Given this list of marker genes CD164, PRMT1, CCNA2, PTMA (NCBI Gene Id 91418), DYNC2I2, TES, FABP5, MYH2, ATAD2, RPS3A, CKS2, CCT5, URI1, ACTL6A (NCBI Gene Id 9178), RPL17, S100A6, RPS7, TSPAN3, AGFG1, MCM7, ZWILCH, YWHAH, DEK, RWDD1, ZNF37BP (NCBI Gene Id 7588), UBA2, CENPU, YBX3, IER3, HDDC2 (NCBI Gene Id 51020), RPS11P1, DYRK2, TUBA1B, ATP5F1C, GTPBP4, ZNF138, RPL31, RBX1 (ring-box 1), RPL35, DYNLT1, RMI2, SMC2, RPL38, MTHFD2 (methylenetetrahydrofolate dehydrogenase (NADP+ dependent) 2, methenyltetrahydrofolate cyclohydrolase), RALA (NCBI Gene Id 5898), TPRKB, ANLN, HNRNPA1, TMSB4X, LRRCC1, TOPBP1, VCL, PTGR3, CCNB1, DCTPP1, DYNLL1, YWHAQ, B3GNT5, RPS18, HNRNPC, OLIG2, LSM8, RPE, RPL27, H4C1 (NCBI Gene Id 8359), CDK4, SLBP, LYAR (Ly1 antibody reactive), PRMT2, BCAT1, PTBP3, ACTR3, ECT2, EIF4A3, KLF5, MRPL42, VCP, PCLAF, RPS5, CENPF (NCBI Gene Id 51468), DBNDD2, H4C3, SNRPG, CDCA8, RPL9, JPT1, RPS6, MSH6, LAMB1, INAVA, DEPDC1, TTK, RPS3, MFSD10, SUMO2, NFE2L3, YWHAB, RBM17, ANXA3, CD2AP, ITGB1BP1, CTBP2, UBE2T, SNRPB2, PELI1, SLC34A1, SERPINH1, KIF5B, HMGB2, PNP, ARHGAP18, RGS2 (NCBI Gene Id 5997), OPLAH, SFT2D1, BUB3, PHLDA2, LXN, NTS, SLC44A1, NSF, RAN, CALM2, DLGAP5, MCM6, MAPRE1, KNTC1, MARCKS, KRT10, METTL5 (methyltransferase 5, N6-adenosine), ZNF532, DSG2, ANXA4, PCNA, PBX1, MMD, SPC25, CBX3, RPL36A, PDCD5, RCC2, FBL, NLRP2, ATP2B1 (NCBI Gene Id 490), NOP56, HIF1A, SET, RAB32, UBE2D1, ZNF681, EEF1E1, NAP1L1, KRT19, ODC1, CLIC1, NDC1, RPL12, RPSA, ITPR3, NPM1, PFDN4, HMGN1, BZW2, HDAC2, IGF1R, USP1, RPS9, CCDC6, SUZ12, SEPTIN7, PDLIM7, PLP2, MCM2, NCBP2, ZC2HC1A, H4C14, RND3 (Rho family GTPase 3), CCT6A, KHDRBS1, AGRN, DUSP18, here is a description of the gene set: Genes highly expressed in hepatocellular carcinoma with poor survival. Human Gene Set: LEE_LIVER_CANCER_SURVIVAL_DN species: Homo sapiens from publication Lee JS, Chu IS, Heo J, Calvisi DF, Sun Z, Roskams T, Durnez A, Demetris AJ, Thorgeirsson SS (PMID 15349906) We analyzed global gene expression patterns of 91 human hepatocellular carcinomas (HCCs) to define the molecular characteristics of the tumors and to test the prognostic value of the expression profiles. Unsupervised classification methods revealed two distinctive subclasses of HCC that are highly associated with patient survival. This association was validated via 5 independent supervised learning methods. We also identified the genes most strongly associated with survival by using the Cox proportional hazards survival analysis. This approach identified a limited number of genes that accurately predicted the length of survival and provides new molecular insight into the pathogenesis of HCC. Tumors from the low survival subclass have strong cell proliferation and antiapoptosis gene expression signatures. In addition, the low survival subclass displayed higher expression of genes involved in ubiquitination and histone modification, suggesting an etiological involvement of these processes in accelerating the progression of HCC. In conclusion, the biological differences identified in the HCC subclasses should provide an attractive source for the development of therapeutic targets (e.g., HIF1a) for selective treatment of HCC patients. Supplementary material for this article can be found on the HEPATOLOGY Web site (http://interscience.wiley.com/jpages/0270-9139/suppmat/index.html)